The following is a description of a gene set: The morphogenetic process in which an epithelium narrows along one axis and lengthens in a perpendicular axis contribution to the shaping of an organ. Mouse Gene Set: GOBP_CONVERGENT_EXTENSION_INVOLVED_IN_ORGANOGENESIS species: Mus musculus, and this is the list of marker genes: Frzb, Wnt5a, Zfp568, Dvl2, Vangl2, Mesp1, Dvl1